Given this list of marker genes MOAP1, GPA33, IP6K2, ITGA6, ZNF165 (NCBI Gene Id 7718), ADGRE2, TRMT12, TTN, SMCR8 (SMCR8-C9orf72 complex subunit), FNDC4, CXCL16, ZNF281, ELF2, CSRNP2, RBSN, CUL3, IQSEC1, BPGM, MAX, JADE1, BCL2L11, CACNA1I, PLEKHH2, PPARGC1B, TNIP2, RHBDD2, SH2B3, RPF1, ZNF268, NOM1, CCDC86, SPATA2, SMAD1, TGFBR2, BACH1, REL, RING1, LTV1, VPS37B, SNORD89, IFRD1, ZBTB10, ELOA, JOSD1, ZRSR2P1, UTP15, QTRT2, BLOC1S4, SNORD104, ZC3H12A, DNAJC25, RYK, MAT2A, SECISBP2, PHF20L1, FBXL3, KMT2C, ARID4B, DNAJB12, ZHX1, IRS2, SVIL, TMEM243, SYNCRIP, DDX20, MCRS1, MTMR9, DDX21, ATXN1L, C6orf120, CRBN, DHX8, ZNF3, ERLEC1, MARCHF8, GORAB, TEX261 (NCBI Gene Id 113419), NOL6, RAPGEF6, NET1, CTU2, TRIB1, RPL26L1-AS1, FAM3C, DUSP11, C1orf56, TBC1D23, PROSER2, PDZD8, RAB30, BCCIP, MAPK1IP1L (mitogen-activated protein kinase 1 interacting protein 1 like), YTHDF1, ZNF326, RPP38, RMND5A, CAST, DGCR11, SLC25A33, TRMT6, FCN1, ARL8B, IKZF5, SLC5A6, SURF2 (NCBI Gene Id 6835), PRKD3, RHOH, IER5, ERMN, DDX3X, MOB1B, PTP4A1, FYTTD1, ZNF324, ATP6V1G1 (NCBI Gene Id 9550), FKRP, NOTCH1, PRMT9, GPR65, ZNF256, LYSMD2, WDR47, ZNF843, NFKBID, USPL1, PUS3, VEZF1, FAM53C, TNFAIP6, VCPKMT, NXT1, NUP54, GTPBP4, SPTY2D1, TTC19, TAGAP, CRY1, HIVEP1, NOP58, PFN2, KBTBD2, ANKRD28, TNFSF14, TFIP11, SNX9, GPR132, DNAJB9, FAM91A1, PARP8, CEMIP2, TECPR1, ASTE1, NAP1L5, FOSB, MYNN, KANSL2, DUS3L, PPIL4, DDX19B, LEF1-AS1, ENSG00000274253, TSPYL2, SIK1, ERP27, ALG13, AKAP8, CTSL, CD69, ARHGAP21, TCTA, ADNP2, ANXA1, ZFP36, SYNM, IL7R, TMEM201, NSMCE3, SLC25A32, TIMM23, MTMR3, TSSC4, MYC, POSTN (NCBI Gene Id 10631), ZMPSTE24, FAM222B, ZNF202, MORC2-AS1, BRPF1, DNAJA4, NOSIP, FCMR, SCYL2, ZNFX1, JMY, CCNY, GEM, DTNBP1, here is a description of the gene set: The aim of this dataset was to study in detail the transcription kinetics initiated by cytokine IL-4 in early differentiation of Th2 cells. Genes up-regulated in comparison of untreated CD4 T cells at 1 h versus the untreated cells at 72 h. from publication Elo LL, Järvenpää H, Tuomela S, Raghav S, Ahlfors H, Laurila K, Gupta B, Lund RJ, Tahvanainen J, Hawkins RD, Oresic M, Lähdesmäki H, Rasool O, Rao KV, Aittokallio T, Lahesmaa R (PMID 20620947) Human Gene Set: GSE17974_1H_VS_72H_UNTREATED_IN_VITRO_CD4_TCELL_UP species: Homo sapiens